Given this list of marker genes ARL4A, FBXL22, TACC2, TINAGL1, PPP1R12B, FENDRR, DUSP2, KLF2, CHRDL1, HPSE2, MAFF (NCBI Gene Id 23764), PLP1, CDKN1A, SYNGR2, MYOCD, BRINP3, FLRT2, PCSK7, AKAP1, MYH11, SBSPON, SVIL, SYNPO2, HHIP-AS1, LEFTY2, KIAA0408 (KIAA0408), LMCD1, C16orf89 (chromosome 16 open reading frame 89), GADD45G, ACTG2, RRAD, RASL11A, CAP2, DES, ITGA9, THBS2, SLC16A3, SEMA3C, PDLIM3, EPCAM, LGR6 (leucine rich repeat containing G protein-coupled receptor 6), MTSS1, SLC25A4, NR4A2, ADAMTS8, HHIP, MT1X, FGF18, HSPB7, KCNMB1, SLMAP, FNDC1, IRAG1, GBP2, ENTPD1-AS1, COL4A6, ADAMTS5, LMOD1, NR4A3, LDLRAD4, FILIP1L, CNN1, GLIPR1, TSPAN7, WFDC1, SPEG, ADAMTSL2, CRIP1, PDGFC (NCBI Gene Id 56034), WNT5A, DTNA, ARHGAP42, CSRNP1 (NCBI Gene Id 64651), RAMP1, GEM, CD9, KLHL23, FOSL2, SIK1, CCDC3, NET1, LRIG1, CSRP2, SCUBE1, IL4R, GREM2, NR4A1, SGCA, ZNF536, IGF1, SEMA3E, CXADR, GALNT18, MRGPRF, FHL2 (four and a half LIM domains 2), TSPAN2, IL13RA1, LTBP2, ENTPD1, ASB2, CACNB2, NTN1, TOB1, FBXO32, RBM38, ATF3, LUZP2, SSC5D, TSPAN18, CRISPLD2, THSD4, MAOB, COL4A5, IL21R, TGFBR3, here is a description of the gene set: species: Homo sapiens Human Gene Set: HE_LIM_SUN_FETAL_LUNG_C0_LATE_AIRWAY_SMC_CELL Late airway SMC from publication He P, Lim K, Sun D, Pett JP, Jeng Q, Polanski K, Dong Z, Bolt L, Richardson L, Mamanova L, Dabrowska M, Wilbrey-Clark A, Madissoon E, Tuong ZK, Dann E, Suo C, Goh I, Yoshida M, Nikolić MZ, Janes SM, He X, Barker RA, Teichmann SA, Marioni JC, Meyer KB, Rawlins EL (PMID 36493756)